Given this list of marker genes Ing2, Sin3b, Brms1, Tet1, Brms1l, Ogt, Arid4a, Hdac1, Sap130, Rbbp7, Sinhcaf, Csnk2a1, Hdac2, Phf12, Arid4b, Sap30l, Ing1, Rbbp4, Sin3a, Suds3, Sap30, Morf4l1, here is a description of the gene set: Mouse Gene Set: GOCC_SIN3_TYPE_COMPLEX studied in species Mus musculus Any of a number of evolutionarily conserved histone deacetylase complexes (HDACs) containing a core consisting of a paired amphipathic helix motif protein (e.g. Sin3p in S. cerevisiae, Pst1 in S. pombe or Sin3A in mammals) at least one class I histone deacetylase (e.g. Rpd3p in S. cerevisiae, Clr6 in S. pombe, or HDAC1 and HDAC2 in mammals), and at least one WD40 repeat protein (e.g. Ume1p in S. cerevisiae, Prw1 in S. pombe, or RbAp46 and RbAp48 in mammals). These complexes also contain a variable number of other proteins that direct histone binding, DNA binding, or add other functionality to the complex.